Given this list of marker genes DLL4, PLEC, BMS1, MCTP2, ITGB4, CDH1, UBA2, here is a description of the gene set: A developmental defect resulting in the congenital absence of skin on the scalp vertex, often just lateral to the midline. Human Gene Set: HP_APLASIA_CUTIS_CONGENITA_OVER_THE_SCALP_VERTEX studied in species Homo sapiens Aplasia cutis congenita over the scalp vertex